Given this list of marker genes GART, CREBL2, GLUD1, NUTF2, GLRX2, DHFR, RANBP1, MCM3, ZNF595 (zinc finger protein 595), WDR47, DDX46 (NCBI Gene Id 9879), ESCO2, DEPDC1, ORC6, DTYMK, ABCE1, NUDT21, DCAF12, PRC1, KIF2C, SGO1, IQGAP3, RPA3, PCNA, PLK4, PIMREG, CYCS, NDC80, SLC37A4, RRM2, UBE2C, NME4, TROAP, GTSE1, OFD1, RNF168, TBC1D10B, GTF2B (general transcription factor IIB), CCDC34, KLHDC1, MCM7, IKBKG, RAN, KIF23, TUBGCP3, FAR2, RABL3, RNASEH2A, PCID2, GTF2F1, SVIP, CEP43, RPF2, DR1, CDKN3, HMGB1, IDH2 (isocitrate dehydrogenase (NADP(+)) 2), SNRPB, H2AZ1, BHLHE40, FUNDC1, H2AX, HMGN2, C4orf46, NUSAP1, CREB5, DNAJA4, TACC3, STIL, ERI3, CCDC18, SKIC8, PNPT1, XRCC4, MGAT2, UHRF1, ZWINT, CKAP2L, ENSG00000274253, KIF22, NDUFA6, PPP1R15A, KIF4A, ALG3, SGO2, WDHD1, GGCT, CCNB2, CENPH, VCP (NCBI Gene Id 94731), CDCA3, FAM83D, SAP30, XRCC3, ZDHHC12, ORMDL2, BARD1, C1orf122, ICAM3, ANLN, ASPM, GINS2, CCNB1, MCAT, TMED9, PA2G4, CDC123, GALE (NCBI Gene Id 2582), KIF20B, H4C3, PSME2, ATAD2, SKA3 (spindle and kinetochore associated complex subunit 3), PIGA, BUB1, IL10RB, TRIP6, CD58, MRPL37, BRCA2, NFATC2IP, RAD21, ANAPC5, MTIF3, PCLAF, WDFY1, DHCR24, GMNN, FAM111A, TMEM14B, PAXX, UBE2T, CHCHD2, EBNA1BP2, POP4, WDR54, TPX2, LSM2, SLC35F5, DEK, PHF19 (NCBI Gene Id 26147), CTPS1, RBBP7, HIRIP3, CKS1B, IPO5, CDK1, MRPS12, PBK, RCC1, ASAP1, HSPA1B, TOP2A, HMGB2 (NCBI Gene Id 3148), SRSF7, AK2, COQ2, PDCD5, BUB3, PPP2R3C, CKS2, TK1, RFC4, DUSP11, TPRKB, CCR1, MICU1, MCM6, PYM1, SPC25, NCAPD2, TBCD, MGME1, TAF4, ZNG1C, MRPS22, TXNDC17, CENPS, CENPF, CRYBB1, HMMR, SPAG5, SPNS3, TEX30, CACYBP, CYTOR, CCNF, AURKA, RMDN1, KIF11 (NCBI Gene Id 3832), PHF12, FEN1, CDCA8, TCF19, GINS1, MRPL42, CISH, TUBA1B, NEDD1, ILF2, GAMT, PCSK7, DVL2, VPS36, MRPL20-AS1, NUCKS1, SRSF3, CCNA2, CKAP2, RHEB, NASP, TMEM256, NSMCE4A, DIAPH3, GLT8D1, SEC13, ABHD13 (NCBI Gene Id 84945), PAICS, SRSF1, QDPR, SS18L2, COA8, TMEM170A, UCHL3, ASF1B, MCM4, AP2S1, HJURP, KPNA2, LENG1, CDCA5, DUT, SHCBP1, NUF2, PLK1, PIK3R4, TMPO, ARL4A, DSN1, ITGB3BP, RFC2, POLE3, TMEM106C, NRM, AURKB, DDX39A, BIRC5, TIMM10, MPC1, TECR, ID1, CDCA4, TMEM107, TRAF3IP2, RRP1, TRAPPC2L, HELLS, here is a description of the gene set: from publication Zhong S, Zhang S, Fan X, Wu Q, Yan L, Dong J, Zhang H, Li L, Sun L, Pan N, Xu X, Tang F, Zhang J, Qiao J, Wang X (PMID 29539641) Human Gene Set: ZHONG_PFC_C1_MICROGLIA studied in species Homo sapiens